The following is a description of a gene set: studied in species Homo sapiens from publication Chen Y, Wang X (PMID 31504780) Genes predicted to be targets of miRBase v22 microRNA hsa-miR-548ba in miRDB v6.0 with MirTarget v4 prediction scores > 80 (high confidence targets). Human Gene Set: MIR548BA, and this is the list of marker genes: PWWP2A, PDE6C, SLC25A12, PF4, SLC17A6, RFXAP, STAM, CD164, CMTM4, WDR20, VAPA, LCOR, BACH2, NFYB, RNF38, ZNF43, SEMA3C, CRNKL1, PKD2, PAK2, CDH19, RWDD4, KDM2B, ZNF585B, HMCN1, TMPRSS11B, TMEM200A, RBMXL3, GASK1B, LPP, RREB1, PIK3C2B, UBE2E3, PCDH15, PCDH18, OBSL1, PPP1R3B, PDLIM5, NEUROD1, BMP3, CENPK, HPCAL4, FBXL4, MAP7, CYP2J2 (NCBI Gene Id 1573), TCFL5, LNX2, NELL2, RIOX1, POLR3G, ULK2 (NCBI Gene Id 9706), PRDM4, RGL1, SETD9, TVP23A, FIP1L1, TCERG1 (NCBI Gene Id 10915), SPDYE3, NEK2, HSPA4L, NFE2L3, ITPR3, NEMP1, ZNF730, DENND1A, BICD2, EPSTI1, DIXDC1, TMEM229A, MPRIP, RDX, CRISPLD1 (NCBI Gene Id 83690), KRTAP9-9, P2RY12, ANKRD13A, EHBP1, RHOA, ZHX2, SASS6, GUCY1A2, TYMSOS (NCBI Gene Id 494514), NCKAP1, MTUS1, SPDYE1, CERT1, PSME3, OIP5, EFEMP1, APPBP2 (amyloid beta precursor protein binding protein 2), SPDYE5, DCAKD, RGS9BP, ZC2HC1C, U2AF1, TRIP11, PDE7A, GPM6A (glycoprotein M6A), ZNF461, MORC3, TNKS2, SPCS3, GABARAPL1, ENSG00000275895, UBE2W, ANKRD17, PCMTD1, MFN1, TNIK, PPP3R1, MOB1B, PABPC5, USP42, B3GNT5, RORB, PSMD7, INSIG1, C1orf115, TOMM5, PURB, LSM8, HELQ, ITSN1, CEP78, ZNF699, ZNF362, SLC15A1, CEP97, IQCK (NCBI Gene Id 124152), GDNF, SON, PWP1, SP110, BRMS1L, MRO, LAMTOR5, COX5A, QKI, GNG12, ZNF716, SMAD2, TP63, C4orf46, TNRC6C (trinucleotide repeat containing adaptor 6C), CAMSAP2, PSMA8, C21orf91, DICER1, COG5, MBNL3, DENND4C (NCBI Gene Id 55667), TPR, AMER2, SVIL, ZEB2, CDC14A, ELOVL5, ZNF777, PDHA1, DCP2, TRIM13, STAU2, ENPP4, ZNF770, BCAT1, ZDHHC21, TMEM178B, SPDYE6, IFIT1B, EPHB1, LMBR1